Given this list of marker genes TUBA1A, TBC1D20, SNRPN, NDN, TGIF1, OCA2, ZIC2, SRPX2, ADGRG1, GAS1, RAB3GAP1, ATP1A2, ATP1A3, TUBB2B, FOXH1, PI4KA, SHMT2, SIX3, MAPK8IP3, MAGEL2 (NCBI Gene Id 54551), STIL, CRIPTO, CDON, SHH (NCBI Gene Id 6469), GLI2, MTOR, PTCH1, DISP1, NANS, MICU1, NODAL, DLL1, FGF8, BICD2, MYCN, here is a description of the gene set: Perisylvian polymicrogyria species: Homo sapiens Polymicrogyria (an excessive number of small gyri or convolutions) that is maximal in perisylvian regions (the regions that surround the Sylvian fissures), which may be symmetric or asymmetric and may extend beyond perisylvian regions. The Sylvian fissures often extend posteriorly and superiorly. Human Gene Set: HP_PERISYLVIAN_POLYMICROGYRIA